The following is a description of a gene set: Genes up-regulated in the liver tissue from 10 week old male mice with KLF10 compared to wild-type littermates. species: Mus musculus from publication Guillaumond F, Gréchez-Cassiau A, Subramaniam M, Brangolo S, Peteri-Brünback B, Staels B, Fiévet C, Spelsberg TC, Delaunay F, Teboul M (PMID 20385766) Mouse Gene Set: GUILLAUMOND_KLF10_TARGETS_UP The circadian timing system coordinates many aspects of mammalian physiology and behavior in synchrony with the external light/dark cycle. These rhythms are driven by endogenous molecular clocks present in most body cells. Many clock outputs are transcriptional regulators, suggesting that clock genes primarily control physiology through indirect pathways. Here, we show that Krüppel-like factor 10 (KLF10) displays a robust circadian expression pattern in wild-type mouse liver but not in clock-deficient Bmal1 knockout mice. Consistently, the Klf10 promoter recruited the BMAL1 core clock protein and was transactivated by the CLOCK-BMAL1 heterodimer through a conserved E-box response element. Profiling the liver transcriptome from Klf10(-/-) mice identified 158 regulated genes with significant enrichment for transcripts involved in lipid and carbohydrate metabolism. Importantly, approximately 56% of these metabolic genes are clock controlled. Male Klf10(-/-) mice displayed postprandial and fasting hyperglycemia, a phenotype accompanied by a significant time-of-day-dependent upregulation of the gluconeogenic gene Pepck and increased hepatic glucose production. Consistently, functional data showed that the proximal Pepck promoter is repressed directly by KLF10. Klf10(-/-) females were normoglycemic but displayed higher plasma triglycerides. Correspondingly, rhythmic gene expression of components of the lipogenic pathway, including Srebp1c, Fas, and Elovl6, was altered in females. Collectively, these data establish KLF10 as a required circadian transcriptional regulator that links the molecular clock to energy metabolism in the liver., and this is the list of marker genes: Fen1, Mt2, Derl1, Serpine2, Scara5, Cckbr, Saa1, Saa2, Atp8a1, Gpr85, Cd320, Il1f10, Fgl1, Il2rb, Itga4, Wdfy1, Adamts8, Tff3, Ndrg1 (N-myc downstream regulated gene 1), Aldh18a1, Tfap2c, Adissp, Slc25a30, Lasp1, Sv2a, Col16a1, Ywhaz, Asns, Cadm3, Cpt1a, Ccr2, Rgs5, Syt11, Lpl, Kifc2, Rsrp1, Celsr2, Rdh12, Dnajc18, Steap1, Slc22a7, Nnmt, Mt1, Stom, Nnt, Ugt2b38, Pck1 (NCBI Gene Id 98888), Lcn2, Dag1, Moxd1